The following is a description of a gene set: Mouse Gene Set: GOBP_POSITIVE_REGULATION_OF_IMMUNE_SYSTEM_PROCESS Any process that activates or increases the frequency, rate, or extent of an immune system process. studied in species Mus musculus, and this is the list of marker genes: Ager, Trim3, Fcrl5, Znfx1, Gbp7, Ikbkg, Parp1, Il12b, Ihh, Akirin1, Clec4n, Trim32, Pbrm1, Tomm70a, Hc, Zfp36l1, Nppc, Cd5l, Tnfsf13, Epg5, Ap1g1, App, Nfkbid, Ikzf1, Skint2, P2rx7, Mndal (myeloid nuclear differentiation antigen like), Ccl19-ps3, Tnfsf9, Actl6b, Smarcd1, Ppp6c, Irak1, Lypd11, Traf6, Shld2, Rnf135, Jam2, Cd86, C4b, A2m (NCBI Gene Id 232345), Fam3d, Trim30a, Pik3ap1, Hcls1, Nop53, Crtam, Bmi1, Kitl, Ptger3, Mr1, Ap3b1, Gps2, Adora3, Ifi213, Icos, Aoc3, Lamp1, Slc39a6, Wnt10b, Hmgb2, Becn1, Ifi208, Ninj1, Pcid2, Rnf170, Ccl24, Casp8, Lax1, Cfhr1, Pou4f1, Itgb2, C3ar1, Abl1, Il1a, Rbm14, Ifi209, Oas1e, Sart1, Gata2, Axl, Tox, Cd36, Exosc3, Ddx21, Skint4, Ifi203, H60b, Itgal, Mlh1, Ccr6, Traf2, Rps6ka3, Rif1, Tnfsf11, Mif, Lypd10, C4a, Mapk3, Zdhhc1, Ighg1, Eif2ak4, Trim30d, Klrc3, Wnk1, Tax1bp1, Jam3, Ppbp (NCBI Gene Id 75592), Mcu, Hexim1, Raet1e, Arid1a, Tek, Fpr-rs4, Cd28 (CD28 antigen), Braf, P2rx4, Cxcl1, Tirap, Klrd1, Pck1, Ephb4, Ms4a1, Panx1, Notch2, Cfb, Bad, Il27ra, Peli1, Xrcc5, Ccl3, Fut4, Hmgb1, Il2rg, Gpatch3, Cd4, Phf10, Cd5, Gm12250, Cd83, Myd88, Tnip3 (TNFAIP3 interacting protein 3), Stat5b, H2-K1, Evi2, H2-D1 (histocompatibility 2, D region locus 1), Sirpa, Lyplal1, Bloc1s6, Reg3g, Sin3a, Gpr33, Zcchc3, Ripk1, Cxcl10, Klf10, Nkap, Igf1, Trat1 (NCBI Gene Id 77647), Rc3h1, Nlrp1b, Itga4, Trp53, Eif2ak2, Brd4, Appl1, Card11, Atp11c, Colec11, Ubqln1, Il6, Dhx33, Tarbp2, Tnfsf14, H2-DMb2, Psen2, Tmem64, Ticam1, Cgas, Prnp, Rab7b, Lpxn, Slc7a1 (NCBI Gene Id 264068), Nr1h3, Nek7, Sqstm1, Sirt2, Pnp, Usp50, Gpld1, Bcl6, Akt1, Ifi205, Cd37, Matr3, Irgm2, Pten, Tesc, Aars2, Gsdme, Ccl1, Irf7, Il13ra1, Cd300ld2, Gpr108, Slc4a1, Pdpk1, Nfam1, Ctla4, Enpp3, Acin1, Shld3, Cftr, H2-T22 (histocompatibility 2, T region locus 22), Dhx9, Dhps, Thbs1, Acod1, Zdhhc18 (NCBI Gene Id 503610), Cd24a, Dppa1, Zfp335, Oas3, Stoml2, Cd40lg, H2-Oa, Ifi204 (NCBI Gene Id 15951), Tifa, Edn1, Cxcr2, Susd4, Cd55b, Klrc1, BC037156, H2-T3, Fes, H2-T15, Tac1, Il7r, Masp1, Dlk1, Cd6, Oas1a, Cxcl17, Nagk, H2-Ea, Ptger4, Sirt1 (sirtuin 1), Creb1, Sppl3, Shld1, Fcgr3, Smarca4, Ambra1, Ube2n, Abl2, Pawr, Fcgr1, Blnk, Csnk1a1, Ermap (erythroblast membrane-associated protein), Fpr3, Mavs, Chrnb2, Ocstamp, Tnfrsf21, Rps19, Fpr1, Cd209e, Mzb1, Trim12a, Map3k7, H2-T23, Slc15a4, Csk, Cyba, Trem3, Sox12, Trim25, Ikbke, Rc3h2, Rac2, Lta, Cd80, Lrch4, Trim5, Il1rl2, Timd2, Btnl1, H2-M5, Skint10, Sh2d1b1, Il17a, Smarcc1, Tnfrsf11a, Rasgrp1, Fyn, Ube2k, Btnl4, Ufd1, Dpp4, Cd79a (NCBI Gene Id 12518), Il2, Ccr1l1, Stxbp2, Lcp2, Cd79b, Arid2, Snx4, Cptp, Ccl9 (C-C motif chemokine ligand 9), Adam17, Smarcc2, Zfp609, Shh, Sh2d1b2, Brd7, Hamp, Sh2b2, Ticam2, Pagr1a, Mef2c, Elf1, Casp4 (caspase 4, apoptosis-related cysteine peptidase), Cd300lf (NCBI Gene Id 353028), Elane, Anxa1, Rara, Rbm47, Bcl2, Skint5, Sos1, Nck2, Vsir, Thy1, Tbx21, Cav1, H2-T24, Cd226, Foxp1, Khdrbs1, Hsp90aa1, Adam10, C1qb (NCBI Gene Id 12260), Mad2l2, Evi2b, Usp27x (NCBI Gene Id 54651), Colec10, Il7, Clec4b2, Abhd17a, Aif1, C1qc, C5ar1, H2-Q4, Cd27, Bdkrb1, Tlr7, Nckap1l, Pla2g4a, Polr3c, Fer, Ano6, Igfbp2, Trim11 (NCBI Gene Id 94091), Ifi207, Zdhhc5, Spn, Pdgfd, Pdcd1lg2, Med23, Egr3, Tspan6, Gsk3b, Blvra, C8b, Prkaa1, Rasal3, Pspc1, Ifih1, Xbp1, Lbp, Gimap5, Stxbp1, Btk, Psg22, Dock8, C8a, Gbp5, Klri2, Themis, Ifi203-ps, Ifi214, Slc9b2, Xiap, Zbtb1, Socs1, Trim62, H2-M10.3, Dusp10, Pde4d, Tgfb2, Trp53bp1, Prlr, Plcg1, Il5, Smpdl3a, Klrc2, Irs2, Psen1, Skint7, Irak2, Il16, Klhl6, Pou4f2, Vav3, Hmces, Il3 (interleukin 3), Icam1, Letmd1 (LETM1 domain containing 1), Cblb, Elp6, Tlr3, Ywhag, Oas1f, Thbs4, Stx7, Tlr6, Adk, Clnk, Tyro3, Zbtb7b, Malt1, H2-M10.5, Ccl19-ps1, Casp6, Ido1, Msh2, Prkd1, Tril, Actl6a, Cd320, Tacr1, Klrk1, Aurkb, Gas6, Arrb2, Oas1g, Tnfrsf14, Arg1, Fpr-rs7, Sarm1, Ptprj, Mospd2, Fpr2, Cr1l, Cyrib (NCBI Gene Id 76270), Trim31, Plvap, Btnl2, 6030468B19Rik, Cmklr1, Med1, Zfp683, Cd81, Tnfaip3, Id2, Nfatc2, Mstn, Trem1, Pde4b, Kcnj8, Nf1, Cx3cr1, Ppargc1b, Masp2, Ccl20, Hcar2, Tap2, Il23a, Klri1 (NCBI Gene Id 503550), Il20, Skint9, Jund, Jun, Nck1, Trim6, Phb2, Kars1, Fzd5, Edn3, Ccl2, Mir301, Itgb2l, Fcnb, Ascl2, Zmiz1, Havcr2, Smpdl3b, Ywhae, H2-DMb1, Nsd2, Hcfc2, Slc46a2, Stk11, Fut7, Cd59b, Slc19a1, Vegfd, Lilrb4b, Selp, Ddrgk1, Serpine1, Ccl7, Eeig1, S100a8, Lime1, Ighg2b, Park7, Vegfc, Krt1, Xcl1, Selenok, Plcl2, Runx1, Il12rb1, Banf1, Gata3, Blm, Tlr4, Madcam1, Tmem126a, Zbtb46, Mpl, Ccr1, Ppt1, Bcl2a1d, Nppa, Gdi1, C1s2, Car2, Kcnk13, Cd101, Akirin2, Ccl21f, Epo, Klhl25, Skint6, Fyb2, Usp46, Zap70, Stat6, Dapk2, D1Pas1, Nlrx1, Sox4, Cdkn1a, Btn1a1, Ccl21e, Mmp14, Appl2 (adaptor protein, phosphotyrosine interaction, PH domain and leucine zipper containing 2), Tec, Fcna, Ncr3-ps, Ipo5, Cd47, Lag3, Il34, Vamp8, Il4ra, Usp15, F2rl1, Lamp2, Sec14l1, Gfi1, Fgf10, Trex1, Dhx36, Ptk2b, Flot1, Usp9x (NCBI Gene Id 77016), Serping1, Trim15, Ctsg, Il13, Pik3cd, Gli3, Nod2, Prkcq, Nod1, Mmp9, Mfhas1, Gpam, Plcg2, Zp3, Gbp3, Hes1, Asxl2, Plpp6, Rps3, Nlrp6, Trav7-2, Plscr1, Ptpn22, Cd177, Phb1, Irf5, Ephb2, Itga2, Tespa1, Il18, Wdfy1, Nlrp1a, Pla2g7, Txk, Csf1, Smarca2, Naglu, Rbp4, Ccr7, Tgfbr2, Icosl (NCBI Gene Id 50723), Clec2i (NCBI Gene Id 93675), Timd5, Ptgs2os, Cd38, Ada, Cfd, Sphk2, Fbxl2, Dnajb9, Il10, Pvr, Ifnl2, Cd22, Myo18a, Fcmr, Nlrp3, F7, Rnf34, Sema7a, Il18r1, Socs5, Cd300ld, Pms2, Lsm14a, Aim2, Eif2b4, Stat5a, Dusp22, Paxip1, Ptprs, Tbk1, H2-M10.6, Slc15a2, Klre1, Mir223, Rnf144a, Arid5a, Otud4, P4hb, Ighm, Pla2g5, Syk, Tnf, Lrrfip2, Cmtm3, Mapk1, H2-Ab1, Lgmn, Lck, Gbp2b, Tslp, Tlr1, Rab29, Irf2, Gprc5b, Cd14, Cd276, Adam8, Cd274, Flot2, Klrb1c, Il12a, Fgr, Stap1, H2-M10.4, Il21, Actb, Lif, Ceacam1, Ighg3 (NCBI Gene Id 380795), Mia3, Slc39a10, Vnn1, Hspd1, Vcam1, Mbl1, Ctsc, Tfrc, Pgc, Mapk8, Tnip1, Tlr2, Ptpn6, Parp9, Kat5, Trem2, Cyld, Kmt5b, Nras, Ddx60, Itpkb, Card9, Blk, Prkca, Colec12, Crhr1, Ighd, Hlx, Polr3b, Eif2b2, Trim30c, Zdhhc3, Slc11a1, Pycard (PYD and CARD domain containing), Cebpa, Lats2, Trpv4, Dgkz, Zdhhc4, Ighg2c (immunoglobulin heavy constant gamma 2C), Ppp3ca, Swap70, Ubr2, Gm15441, C7, Aqp3, Creb3, Tgfb1, Fosl1, Clcf1, Nfkb1, Il1rl1, Mmp8, Tlr11 (toll-like receptor 11), Zp3r, Cd74, H60c, Ccl21b, Sting1, Gramd4, Klhl22, Oxsr1, Sh2d1a, Chuk, Itpripl1, Gimap3, Lgals8, Rela, Il1b, Cxcl13, Il4i1, Cd300a, C1ra, H2-Q7, Fosl2, Smarcb1, H2-Q10, Cd46, Nfkbiz, Rabgef1, Plscr2, Ereg, Usp29, Vsig4, Tab1, Fcer2a, Tasl, Cd2ap, Gpr31b, Rac1, Laptm5, C3, Rbck1, Mir326, Klk5, Cd160 (NCBI Gene Id 99838), Hpx, Ddx1, Itga2b, Ezr, Nedd9, Oas1c, Lat2, Zc3hav1, Oas1b (NCBI Gene Id 23961), Nploc4, Zbp1, Cd209c, Cfhr2, Nlrc3, Tcf3, Polr3g, H2-Q1, Otulin, Tnip2, Dcstamp, Ripk2, Defb25, Nlrc5, Vegfb, Lgals1, Xrcc6, Fyb1, Rarres2, Ccdc88b, Cxcl14, Fcer1a, H2-T13, Ccl21a, Flt3l, Ogt (O-linked N-acetylglucosamine (GlcNAc) transferase (UDP-N-acetylglucosamine:polypeptide-N-acetylglucosaminyl transferase)), Dysf, H2-Eb2, Fbxo38, Il6st, Il17f, Calr, Src, Slamf1, Cfhr4, Tlr5, Clec4d, H2-DMa (NCBI Gene Id 14998), H2-Q6, Il1r1, Brd2, Dnm1l, Ptprc, Bax, Pecam1, Crkl, Tyk2 (NCBI Gene Id 54721), Spi1, Ccl19-ps6, Hps1, Cacnb4, Coro1a, Lat, Itgb3, Fcho1, Eif2b3 (NCBI Gene Id 68862), Pram1, Nr5a2, Ptn (NCBI Gene Id 19242), Cfh, Slamf6, Rnf125, Irf4, Rab11fip2 (NCBI Gene Id 74998), Btnl10, Cadm1, Gata1, Prkcb, Mark4, Treml4, Pgf, Stx4a, Pld2, Oasl1, Polr3f, Lgals9, Bst1, Mir324, Trim30b (NCBI Gene Id 244183), Opa1, Jak2, Nr4a3, Slc15a3, Sfpq, Polr3d, Ptpn2, Lyve1, C1rl, P2ry12, Eif2b5, Efnb1, Bag6, C4bp, H2-Eb1, Cd1d1, Il15, Znrf1, Tlr8, Atad5, Hax1, Csf1r, Pik3r6, Hras, Vtcn1, Gpr183, Pqbp1, Spta1, H2-M9 (NCBI Gene Id 14997), Hk1, Znrf4, Myo1f, Wnt5a, 2410137M14Rik, Fos, Nr1h4, C2, Brcc3dc, Cd8a, Il4, Trim56, Mdk, Hsf1, Trim41, Tafa3, Ccl12, Cfp, Ep300, Cd3e, Sh3kbp1 (NCBI Gene Id 80469), Tlr13, Cd300ld4, Dab2ip, Lacc1, Gpi1, Inpp5d, Adora2b, Pja2, Esr1, Btnl6, Bcl10, Zc3h12a, Prkcz, Spon2, Ifi206, Ephb6, Ccr2, Skint11, Ccl21d, H2-M10.2, Mapkapk2, Nmi, Mbl2, Tnfrsf13c, S100a9, Pomc, Ppp2ca, Gab2, Sele, Vegfa, Perp, Cnr1, Ap3d1, Ifi35, Ffar2, Ltf, Bcar1, Ms4a2, Fpr-rs3, Lilrb4a, Gpsm3, Grb2, Cd300ld3, Btn2a2, C1qbp (NCBI Gene Id 28127), Gbp2, Traf3ip3, Kcnn4, Sash3, Alpk1, Il2ra, Clec7a, Mapkapk3, Pum2, Vav1, Hrg, Slc22a13, C1qa, Lrrk2, Gpr68, Cd55 (NCBI Gene Id 13136), Rnf185, C6, Eif2b1, Smarcd2, Cd44, Gfi1b, Efnb3, Ighe, C9, Ptafr, Tlr12, Zfp580, Tnfrsf18, C1rb, Cd1d2, H2-Ob, Bmx, H2-M10.1, Hspa1b, Pla2g3, Smarcd3, Rgcc, Ifnl3, Tnfsf4, Ccl19-ps5, Ifi211, Igha, Klk7, H2-M1 (NCBI Gene Id 333725), Ifng, H2-Aa, Dennd1b, Mmp12, Pik3cb, Crp, Rnf115, Cd99l2, Wnt3a, C1s1, Tnfrsf4, Inava, Hsph1, Ctnnbip1, Hspa8, Cx3cl1, Nlrp10, Clpb, C5ar2, Nectin2, Tmem102, Prkd2, Nono, Rag1, Ulbp1, Ly96, Irgm1, Nos2, Itk, Tmigd3, Timd6, Zdhhc9, Jak3, Ecsit, Rapgef1 (Rap guanine nucleotide exchange factor (GEF) 1), Prkch, Lep, Sox13, Igtp, Foxp3, Rhoa, Irf3 (interferon regulatory factor 3), Skint3, Stk39, Lyst, Cd209d, Klrh1, Rb1, Skint8 (NCBI Gene Id 639774), Lipa, Cpt1a, Cxcl12, Crlf2, Cd244a, Ccdc134, Brcc3, Stmp1, Carmil2, Btnl12, Prkdc, C8g, Plekha1, Exosc6, Smarce1, Cbfb, Tyrobp, Tnfsf13b, Lyn, Ccl5, Oas1d, Tifab, Rtn4, Cactin, Ripor2, Ankrd17, Nfkbia, Fpr-rs6, Skint1, B2m, Cd40 (NCBI Gene Id 98930), Ror2, Irak3, Gcsam, Igf2, Kmt5c, Clec4e, Azgp1, Il18rap, Arf6, Sell, H2-M11, Rnf31, Unc93b1, Irf1, Il15ra, Cd247, Kit, Cd19, Themis2, Nfkbil1, Lgr4, Oas1h, Tlr9, Runx3, Ednra, Galnt2, Rptor, Washc4, H2-T5, Ppp2r3c, Bloc1s3, Pum1, Nr1d1, Rsad2, Dhx58, Traf3, Rap1a, Shb, Cd300lb, Tkfc, Lats1, H2-Q2, Rhoh, Spsb3, Myo1g, Pvrig (NCBI Gene Id 102640920), Itgam, Foxj1, Dusp3, Tescl, Lrrc19, Peli3, Gnas, Zdhhc12, Cacnb3, H2-M2, Camk1d, Riok3, Sla2, Rftn1, Btrc, Rasgrp4, Cfi, Htr2a, Usp12, Ddx3x, H2-M3, Cd59a, Il23r, Phpt1, Usp17le, Btnl9, Ptk2, Mefv (Mediterranean fever), S100a14, Rigi, Prkce, Itch, Raet1d, Lgals3, Skap1, Trim12c, Ffar3, Pcbp2, Scimp, Fadd, Nlrc4, Tnfsf18, Pik3r1, Ccl19, Trib1, Ccl19-ps4, Cd8b1, Atat1, Cr2, Efnb2, Casp1, Dnaja3, Gkn2, Ubash3a, Mog, Ttbk1, Lef1, Il33, Foxo3, Themis3, Srebf1, Il36b, Havcr1, Erbin, Bpifb1, Fcer1g, Lrrc14, Edn2